Given this list of marker genes EME1 (essential meiotic structure-specific endonuclease 1), MSH6, CBLIF, CCDC50, ZSCAN2, ATIC, KLHL5, NDUFA1, MTERF3, LINC00487, POFUT1, TMEM19, COA7, NFKB2, LBHD1, NOP9, PTEN, MCCC2, CALML4, ORAI2, PIP4K2A, IL12RB1, CHAC1, MBOAT2, CEACAM1, SUCLG1, MAGI3, ECE2, LPCAT2, PRPF4, CCT2, CENPA, PHACTR2, TRIP12, RBBP8, ATP5PF, COQ5, PDGFC, FAR2, LTA, S1PR2, PSMA2, TRIP13, HNRNPK, EIF4EBP1, EIF5A (eukaryotic translation initiation factor 5A), GLUD1, NFKB1, LRRC28, NDUFB3, SLC16A1, RPIA, FSCN1, ZNF711, SH2B3 (SH2B adaptor protein 3), TIMM8B, TCF3, PSME1, AMMECR1L, SSBP1, CCDC97, LRRC59, ME2, SORD, STAT1 (NCBI Gene Id 6772), FBLN7, REG4, RNF213, PPP4R2, DNAAF4 (NCBI Gene Id 1867), SLC25A5, C3AR1, BRK1, MBTPS2 (membrane bound transcription factor peptidase, site 2), CTSB, TOMM40L, NICN1, NDUFS3, TMCO1, PLEKHA5, IKZF2, CADM1, ATF4, UQCR10, STIP1, RGS1, COMMD9, PRDX1, CD58, ADSL, EPRS1, MTERF4, IL2RG, CHD7, RFX5, MIR22HG, ITPR2, NIFK, TIFA, COL1A2, ZMIZ1, BCL2L11, UQCRFS1, SOX4, H3C6, WDR4, HMGA1, SNRPD3, COTL1, SLC6A6, TDG, EZH2, CXCL3, FADS1, AHRR, FERRY3, ZNF827, GAPDH, TP53, ZNF106, PHKB, LMO4, ST6GALNAC1, SQOR, ADAMTS6, PGK1, PAK1, RRM2, ANXA2, SLC7A5, TXNDC16, ZC3HAV1L, PPP1CC, FCGBP, INTS7, CRNDE, CEP83, ITGAE, PUF60, METTL8, CLCN5, KCTD20, PSMC4, TMEM135 (NCBI Gene Id 65084), BTN2A2, LRRC2, KNL1, VPS26B (VPS26 retromer complex component B), NDUFAF8, BAX, NUP62, GRK3, ATP1B1, NUTF2, TMSB4Y, ZMYM4, TARS1, CDR1, NEIL3, RCN1, COX6A1, RXYLT1, CCRL2, DENND1B, APRT, SSR3, MRPL14, KARS1, NME1, C16orf46, IKZF4, NFE2L3, PTX3, HSPE1, CD38, ZNF154, AIF1L, PSMD14, UQCC2, DYNLL1, PLEKHG1, ECHDC1, CXCL2, PKIG, DACH1, B3GNT2, PTPRK, MRPS6, CTSL, ABCC1, PIK3C2B, TMTC4, CISD1, IGSF11, CDK2AP1, TIPARP, OSBPL11, NDUFS4, CTSC, here is a description of the gene set: Genes up-regulated in comparison of fetal conventional T cells versus adult conventional T cells. from publication Mold JE, Venkatasubrahmanyam S, Burt TD, Michaëlsson J, Rivera JM, Galkina SA, Weinberg K, Stoddart CA, McCune JM (PMID 21164017) studied in species Homo sapiens We compared differences in fetal and adult T cells by performing whole genome profiling on sort-purified T cells (naïve CD4+ and Treg cells) from human fetal specimens (18-22 gestational weeks) and adult specimens (age 25-40 years old). Fetal and Adult Naïve CD4+ T cells phenotype: CD3+CD4+CD45RA+CCR7+CD27+, Fetal and Adult CD4+CD25+ Treg phenotype: CD3+CD4+CD25bright Human Gene Set: GSE25087_FETAL_VS_ADULT_TCONV_UP